Given this list of marker genes MMP3, JUP, COL1A2, CDH6, FN1 (fibronectin 1), ICAM1, ITGB2, ARHGDIA, RHOC, COL3A1, DVL1, LRP1, RHOG, COL6A3, MARCKSL1, MMP14, TIMP1, TIMP3, COL6A1, CYTH2, PCDHGC3, here is a description of the gene set: species: Homo sapiens Human Gene Set: VERRECCHIA_RESPONSE_TO_TGFB1_C2 Cluster 2: ECM related genes up-regulated in dermal fibroblasts within 30 min after TGFB1 addition; reached a plateau after that. from publication Verrecchia F, Chu ML, Mauviel A (PMID 11279127) Despite major advances in the understanding of the intimate mechanisms of transforming growth factor-beta (TGF-beta) signaling through the Smad pathway, little progress has been made in the identification of direct target genes. In this report, using cDNA microarrays, we have focussed our attention on the characterization of extracellular matrix-related genes rapidly induced by TGF-beta in human dermal fibroblasts and attempted to identify the ones whose up-regulation by TGF-beta is Smad-mediated. For a gene to qualify as a direct Smad target, we postulated that it had to meet the following criteria: (1) rapid (30 min) and significant (at least 2-fold) elevation of steady-state mRNA levels upon TGF-beta stimulation, (2) activation of the promoter by both exogenous TGF-beta and co-transfected Smad3 expression vector, (3) up-regulation of promoter activity by TGF-beta blocked by both dominant-negative Smad3 and inhibitory Smad7 expression vectors, and (4) promoter transactivation by TGF-beta not possible in Smad3(-/-) mouse embryo fibroblasts. Using this stringent approach, we have identified COL1A2, COL3A1, COL6A1, COL6A3, and tissue inhibitor of metalloproteases-1 as definite TGF-beta/Smad3 targets. Extrapolation of this approach to other extracellular matrix-related gene promoters also identified COL1A1 and COL5A2, but not COL6A2, as novel Smad targets. Together, these results represent a significant step toward the identification of novel, early-induced Smad-dependent TGF-beta target genes in fibroblasts.